The following is a description of a gene set: part of: Tandem pore domain potassium channels TASK 1 and 3 are closely related both structurally and functionally. TASK1 and TASK3 are activated by extracellular acidification and inhibited by decrease in pH. TASK 1 and Task 3 form functional homodimers and heterodimers, however the biophysical properties of TAS1 and TASK3 heteromers are different form parent subunit properties. Reactome Pathway: TWIK-releated acid-sensitive K+ channel (TASK) species: Homo sapiens, and this is the list of marker genes: KCNK3, KCNK9